The following is a description of a gene set: species: Homo sapiens Fifth finger distal phalanx clinodactyly Human Gene Set: HP_FIFTH_FINGER_DISTAL_PHALANX_CLINODACTYLY Bending or curvature of the distal phalanx of little finger in the radial direction (i.e., towards the 4th finger)., and this is the list of marker genes: BBS9, SCAPER, CEP290, GJA1, BBS2 (NCBI Gene Id 583), BBS10, MKS1, SCLT1, NPR2 (NCBI Gene Id 4882), BBS1, BBS7, BBS5, ARL6, LZTFL1, TTC8 (tetratricopeptide repeat domain 8), WDPCP, IFT172, BBS4, IFT27, NPHP1, BBIP1, BBS12, IFT74, SDCCAG8, CEP19, TRIM32, CFAP418, MKKS